The following is a description of a gene set: The attachment of one cardiomyocyte to another cardiomyocyte via adhesion molecules. studied in species Homo sapiens Human Gene Set: GOBP_CARDIAC_MUSCLE_CELL_CARDIAC_MUSCLE_CELL_ADHESION, and this is the list of marker genes: DSP, PKP2, JUP, CXADR, DSC2, DSG2, CTNNA3